The following is a description of a gene set: Genes up-regulated in cells expressing MEN1. Menin is encoded by the tumor suppressor gene MEN1 that is mutated in patients with an inherited tumor syndrome, multiple endocrine neoplasia type 1 (MEN1). Although menin is a nuclear protein and directly binds to DNA through its nuclear localization signals (NLSs), the precise role for each of the NLSs in nuclear translocation and gene expression remains to be elucidated. Here, we show that point mutations in three individual NLSs, NLS1, NLS2, and a novel accessory NLS, NLSa, do not block nuclear translocation, but compromise the ability of menin to repress expression of the endogenous insulin-like growth factor binding protein-2 (IGFBP-2) gene. This repression is not released by an inhibitor of histone deacetylases. Although subtle mutations in menin NLSs do not affect menin association with chromatin, they abolish menin binding to the IGFBP-2 promoter in vivo. Furthermore, each of the NLSs is also crucial for menin-mediated induction of caspase 8 expression. Together, these results suggest that menin may act as a scaffold protein in coordinating activation and repression of gene transcription and that its NLSs play a more important role in controlling gene transcription than merely targeting menin into the nucleus. from publication La P, Desmond A, Hou Z, Silva AC, Schnepp RW, Hua X (PMID 16449969) Human Gene Set: LA_MEN1_TARGETS species: Mus musculus, and this is the list of marker genes: AZI2, FGF13, NUPR1, CASP8, F3, HOXB8, SORBS1, RGS16, FRRS1, BEX1, ITGA5 (integrin subunit alpha 5), CNN1, CRABP1, BCL6B, IGFBP5, HSD17B11, PTER, ANP32A, ADAM19, SNX10, TSPAN7, DDR2, ACOT1, CAVIN3, SALL3